The following is a description of a gene set: Mouse Gene Set: GOCC_PHOTORECEPTOR_DISTAL_CONNECTING_CILIUM studied in species Mus musculus The distal region of the photoreceptor connecting cilium is structurally unique to the photoreceptor and is maintained by retina-specific protein, SPATA7, and its interacting partners RPGR and RPGRIP1. It is essential for photoreceptor sensory cilium stability., and this is the list of marker genes: Cep290, Rpgrip1, Nphp4, Spata7, Rpgr, Ahi1, Nphp1